The following is a description of a gene set: The 22 members of the fibroblast growth factor (FGF) family of growth factors mediate their cellular responses by binding to and activating the different isoforms encoded by the four receptor tyrosine kinases (RTKs) designated FGFR1, FGFR2, FGFR3 and FGFR4. These receptors are key regulators of several developmental processes in which cell fate and differentiation to various tissue lineages are determined. Unlike other growth factors, FGFs act in concert with heparin or heparan sulfate proteoglycan (HSPG) to activate FGFRs and to induce the pleiotropic responses that lead to the variety of cellular responses induced by this large family of growth factors. An alternative, FGF-independent, source of FGFR activation originates from the interaction with cell adhesion molecules, typically in the context of interactions on neural cell membranes and is crucial for neuronal survival and development.<br><br>Upon ligand binding, receptor dimers are formed and their intrinsic tyrosine kinase is activated causing phosphorylation of multiple tyrosine residues on the receptors. These then serve as docking sites for the recruitment of SH2 (src homology-2) or PTB (phosphotyrosine binding) domains of adaptors, docking proteins or signaling enzymes. Signaling complexes are assembled and recruited to the active receptors resulting in a cascade of phosphorylation events.<br><br>This leads to stimulation of intracellular signaling pathways that control cell proliferation, cell differentiation, cell migration, cell survival and cell shape, depending on the cell type or stage of maturation.<br> part of: Signaling by Receptor Tyrosine Kinases species: Homo sapiens Reactome Pathway: Signaling by FGFR, and this is the list of marker genes: FGFRL1, GIPC1, KL, FRS2, KRAS, FGF6, SHC1, FGFR2c, POLR2H, FLRT2, FGFBP1, FGF20 (NCBI Gene Id 26281), FGF18, FGFR2 (fibroblast growth factor receptor 2), RBFOX2, FGF3, NCBP2, KLB, FGFR3, RPS27A, FGF8, FRS3, FGF10, FGF17, UBA52, UBB, TIAL1, FLRT3, HNRNPM, POLR2K, FGFBP3, SPRED1, POLR2F, PIK3R1, HRAS, FGF22, SOS1, FGF23, MKNK1, PTPN11, NRAS, MAPK1, SRC, FGF2, GRB2, BRAF, FGF7, ESRP1, GTF2F2, FGF19, POLR2E, MAPK3, FGFR4, ESRP2, FGF4, TGFBR3, POLR2I, POLR2B, FGF1, FGF16, SPRED2 (NCBI Gene Id 200734), FGF9, PPP2R1A, NCBP1, HNRNPF, PPP2CB, POLR2D, UBC, PPP2CA, HNRNPH1, FGFR2b, POLR2C, FGFBP2, GALNT3, ANOS1, PLCG1, PTBP1, FGFR1, PIK3CA (NCBI Gene Id 5290), POLR2A, HNRNPA1, TIA1, POLR2L, FLRT1, SPRY2, CBL, POLR2G, POLR2J, FGF5, GTF2F1, GAB1